The following is a description of a gene set: Mouse Gene Set: DESCARTES_ORGANOGENESIS_HEPATOCYTES species: Mus musculus from publication Cao J, Spielmann M, Qiu X, Huang X, Ibrahim DM, Hill AJ, Zhang F, Mundlos S, Christiansen L, Steemers FJ, Trapnell C, Shendure J (PMID 30787437) Mouse Organogenesis Cell Atlas (MOCA) DE_gene_main_cluster.csv, fold.change>=1.5, qval<0.05, pval<0.05, and this is the list of marker genes: Sgk2, Slc17a2, Sfxn2, Anks4b, Cyp2c68, Serpina1a, Mettl26, Dop1b (NCBI Gene Id 70028), Inhbc, Cpm (NCBI Gene Id 70574), Gcnt4 (NCBI Gene Id 238786, glucosaminyl (N-acetyl) transferase 4, core 2 (beta-1,6-N-acetylglucosaminyltransferase)), Bbox1, Ugt2b36 (UDP glucuronosyltransferase 2 family, polypeptide B36), Agt, Hsd17b2, Slc27a2, Ticam1, Dpys (dihydropyrimidinase), Phyh, Pon1, Car7, Nipsnap2, Pde4c, Pnliprp1, Gcgr, Gdf15, Stra6l, Pygl, Nr3c2, Lmbrd2, Bcas1, Hnf1b, Synj2, Nab1, Kng2, Alg13, Gm40055, Spp2 (NCBI Gene Id 75396), L3hypdh, Gm16685, Apoc1, Tmem143, Hc, Pnpla3, Gipc2, Creb3l3, A730017L22Rik, Gm19426 (NCBI Gene Id 100502874), Gc, Echdc3, Hnf4aos (NCBI Gene Id 68314), Trf, Hmgcs2, F7, Dqx1, Als2cl, Nostrin, Apoa1, Sult2a8, Glyctk, Gm24233, Bcorl1, Bco1, Saa4, Slc44a3, Serpinf2, Gstz1, Gstt2 (NCBI Gene Id 14872), A2m, Hpx, C8b, Nme6, Ttc38, Nipal1, Baiap2l1, A1cf, Alb, Fmo4, Adk, Mpc2, Itih4, Fabp1, 1810017P11Rik, Kmo, Apoc4, Mst1, Hoga1, Lypla1, Ugt2b34, Mgam, Grb10, Serpinf1, Hnf4a, Rtkn, Acad11, Fkbp11, Aadat, Pla2g6, Kng1, Paqr9, Dffa, Acot4, Bex2, Bphl, Cyp2d22, Rasgrf2, Igsf1, Gpt2 (glutamic pyruvate transaminase (alanine aminotransferase) 2), Abcd3, Dgat2, Cpn2, Gm12602, Ass1, Mgst1, Spink1, 4930405D11Rik, Aspa, Rrbp1, Hjurp, Gm12576, Gsta3 (glutathione S-transferase, alpha 3), Cpn1, Acot12, Akr1d1, B230208H11Rik, 2900005J15Rik, Pxmp4, Apof, 1810034E14Rik, Exoc3l4, Acox2 (acyl-Coenzyme A oxidase 2, branched chain), Dhdh, Zfp395, Abcc6, Otc, Zscan26, Dmgdh, Kcng3, Albfm1, Mmp19 (NCBI Gene Id 58223), Steap2, Fgb, C2, Nek4, Usp18, Lactb2, Itih3, Atp8b1, Lipc, Asl, Gpr39, Pcsk4, Mkrn2os, Selenbp2, Keg1, C8a (NCBI Gene Id 230558), Slc22a8, Akr1c13, Cyp4f15, Mgst2, Grik4, Il1r1, Apoa2, Mocs2, Rtl4, Serpind1, Slc16a12, Plg, Prodh2, Slc25a15, 4732463B04Rik, Cutc, C1rl, Slc2a2, Arfgap2, Gjb1, Gcat, Apoh, Slc23a1, Cyp2d26 (NCBI Gene Id 76279, cytochrome P450, family 2, subfamily d, polypeptide 26), Mlxipl, Cfb, Slc13a3, Qprt, AI182371, 0610005C13Rik, Mocos, Fdps (NCBI Gene Id 99573), Cryz, Dlk1, Gm29571, Tmem176a (NCBI Gene Id 66058), Acnat1, G0s2, Adra1b, 1700110K17Rik, Anxa4, Golt1a, Aqp11, Shbg, Atp4a, Cxcl10, Sh3bgrl2, Gm20426, Cutal, Mfsd13a, Dap, Fggy, Gstm1, Qpct, Dhrs7l, Klb, Grhpr, Pcbd1, Scly, Fpgs, F13b (coagulation factor XIII, beta subunit), Hnf1aos1, Ldlr, Angptl3, Inpp5f, Slc25a48, Plekhg3, Plekhg6, Aldh6a1, Xylb, Nipsnap1, Sytl5, Pctp, Rnf144b, 0610040J01Rik, Slc35d2, Depdc7 (DEP domain containing 7), Acot6, Gm25357, Tst, Cluh, Sord, Herpud1, Gm17023, Foxa3, Lrrc3, Tmem97, Lbp, Ngef (neuronal guanine nucleotide exchange factor), Gm19705, Gldc, Gm16618, Tent5a, Slc25a33, Aldob, Agxt2 (NCBI Gene Id 381001), Gm15638, Tfpi2, Sec14l2, Chka (choline kinase alpha), Hnf1a, Tmem205, Sec24a, Serpinc1, Apom, Pla2g12b, Snd1, A530020G20Rik, Slc7a9, Bche, 4833422C13Rik, Tmprss6, Gss, Anpep, Grk3, Akr1c19, Emp2, Slc22a18, Glud1, Sugct, Pcyt2, Siah2, Steap1, Vcam1, Fgf1, BC024386, Pgm3, Abcc10, Pex14, Gm826, Bhmt2, Slc17a3, Tmem51, Nr1i2, Cfhr2, Sec16b, Necab1, Rhbg, 9930120I10Rik, Rnf128, Mbl1, Kifc3, Pecr (peroxisomal trans-2-enoyl-CoA reductase), Ctps2, Hgfac, Angptl8, Afmid, Pla1a, Bdh1, Gm19666, Fn1, Ebp, Gckr, Cyp2c23, Gpd1, Nadsyn1, C1ra, Gm17227, Mir337, Gm3289, Cideb, Sdr42e1, Hkdc1, Cpb2, Ephx2, E230016M11Rik, 4833411C07Rik, Slc25a10, Dnajc22, Mtarc2, Soat2, Krt20, Cth, Psat1, Sertm1, Stat2, Maob, Gm47889, Pbld2, Ddah1, Fah, Il17rc, Glul, Serpina1b, Sfmbt1, Upb1, 2310039H08Rik, Gm10658, Serpina1c, Bend6, Asgr2, Mcrip2, Iyd, Pter, Cimip3, Cubn, Gulo, Aadac, Gm42109, Ppp4r4, Shfl, Itih2, Proz, Serpina10, Insr, Hdlbp, Fam20a, Serpina6, Ndrg1, F11, Serpina1d, Hykk, Amdhd1 (amidohydrolase domain containing 1), Afm, Agmo, Rogdi, Rps23rg1, 4930517O19Rik (RIKEN cDNA 4930517O19 gene), Gpam, Grb7 (NCBI Gene Id 268479), Serpina1e, Cys1, Ambp, Abcc2, Hpn (NCBI Gene Id 15451), Errfi1, Gm13571, Mfsd4b3-ps (major facilitator superfamily domain containing 4B3, pseudogene), Als2, Ly75, Neu2, Mmd2, Cd302, Habp2, Fkbp5, Tmt1a, Ppara, Hadh, Dhrs9, Kyat1, Gstt1, Gm11476, 4930556M19Rik, Slc19a2, Aldh8a1, H19, Shroom1, Thpo, Chmp4c, Hnf4g, Rhpn2, Sigirr, Sema4a, Apob, Tfcp2l1, Etfa, Mttp, Tmem37, Kif12, Pxmp2, Prox1os (NCBI Gene Id 102632463), Mirg, F2, Pex26, Hgd, 2810459M11Rik, Ugt2b5, C1s1, Pnliprp2, Ocln, Pde6c, Prox1, Dennd5b, Echdc2, Ddt, Faah, Pik3c2g, Proc, Slc47a1, Rtp3, Abcb11, A330069K06Rik, Tcea3, Lss, Itih1, Pdia5, Ccdc125, Wdcp, Gm42614, Ankrd17, Cps1 (carbamoyl-phosphate synthetase 1), F12, Shmt1, Cdhr2, Nr5a2, 4632428C04Rik, Lrpprc, Ftcd, Lonrf3, 1700016L21Rik, Crot, Vwce, R3hdm2, Idi1, Bhmt, Nt5e, Cbs (cystathionine beta-synthase), Hip1r, Sema4g, Adam32, Shld2, Pank1, Sirt3, Ell, Ahsg, 1700007F19Rik, Rgn, Zan, Arl5c, Baiap2l2 (NCBI Gene Id 207495), Gm11457, Osgin1, 1110028F11Rik, Aldh4a1, Frey1, Pah, Bhlhe40, Fabp5, Fgg, Igfbp1, Gm13449 (NCBI Gene Id 118568511), DQ267102, Uroc1, Acsl1, Gys2, Flvcr2, C8g, Rexo4, Ggcx, Gne, Aass, Mtarc1, Pm20d1, Gm27216 (predicted gene 27216), Masp2, Platr22, Preb, Agmat, Cbx7, Gm10069, Agpat2, Dact2, Mvd, Tmem150a, 1700019D03Rik, Slc39a14, Rbp4, Pcsk9, Slc39a5, Abca6, Abca8b, Raph1, Cyp3a13, Them7, Atp8a2, Cda, Fga, Scp2, Smlr1, Selenbp1, Acaa2, Vwa8, Pzp, Timd2, Stard10, Zcchc2, Papln, Chdh, Cyp2c67, Cfi (NCBI Gene Id 12630), Slc7a15, Fmo2, Rnf43, Sdc4, Il15ra, Lect2, Pdzk1, Slc39a4, Afp (alpha fetoprotein), Klkb1, Cyp2c70, Fmo5, Tmem82, Agtr1a, Sh3d19, Rassf6, Pcolce2, Gm41231, Meg3, Gm16958, Slc36a2, Nlrp6, Lcat, Prr16, Phgdh, Tle6, Aldh3a2, Gnmt, C3, Tm4sf4, Fads6, Ugt2b35, Ikbke, 5033403H07Rik, Morc4, H2-Q10, Ackr4, Slc7a2, Phyhd1, Got2, Chst13, Pkhd1, Haao, Galm, Rian, Gm16754, Aldh7a1